The following is a description of a gene set: The process in which the anatomical structures of the liver are generated and organized. Mouse Gene Set: GOBP_LIVER_MORPHOGENESIS species: Mus musculus, and this is the list of marker genes: Il6, Notch2, Lims2, Ifng (interferon gamma), Tnf, Sulf2, Tgfa, Fgl1, Med1, Cdkn2a, Fgf1, Cul3, Smo, Lims1, Tet2, Fgf18 (fibroblast growth factor 18), Il18, Gli1, Cflar, Wnt3a (NCBI Gene Id 22416), Rps6ka1, Ceacam1, Cpb2, Cebpb, Ceacam2, Xbp1, Hpn, Prox1, Lipa, Plau, Tnfaip3, Mki67, Rtn4, Itpr1, Ptn, Mdk